Given this list of marker genes Lrrc75b, Itgb8, Rd3l (retinal degeneration 3-like), Asph, Bcl2l11, Foxk2, Fcho2, Kat7, Zfp275, Thsd7a, Ttk, Vegfd, Stam, Slc24a3, Cdc25b, Sbf2, Emx2 (empty spiracles homeobox 2), Mex3c, Mecp2, Kcns2, Rab10, Nfat5, Rarres1, C1galt1, Cdk19, Ppfia2, Trak1, Ubn2, Zc3h12c, Btbd3, Arfip1, Harbi1, Usp47, Cdkn1b, Nptn, Tnrc6a, Atp2b4, Meox2, Klhl7, Ptp4a3, Hnf4g, Epas1, B4galt5, Kdm7a, Mief1, Tmem38b, Npepl1, Cblb, Slc22a15, Cdh4, Itga9, Mbnl3, Errfi1, Cs, Dennd5a, Bcl7b, Ddx3x, Tmem9b (NCBI Gene Id 80508), Cckbr, Macroh2a1, Ppp6r1, Dgkq, Mitf, Avpr1a, Mast4, Kcnd3, Samhd1, Rab6a, Anapc10, D5Ertd579e, Nbea, Tex30, Nme7, Rgs8, Slc39a13, Cstdc2 (NCBI Gene Id 77705), Rfx7, Fryl, Zfp804a, Rc3h2, Gadd45a, Lrp4, Epdr1, Xkr4, Ube2d3, Acp3, Nin, Med28, Arpp19, Dmrtc1c2, Ppp2r3a, Zbtb3, Hmg20a, Crtc3, Rbpj, Camsap1 (NCBI Gene Id 96963), Mdga2, Nova1, Gpatch8, Nalcn, Kmt2e, Parpbp, Lrp2, Hspa4l, Fam234a, Tnrc6c, Mllt6 (NCBI Gene Id 246198), Avpr1b, Ankrd6, Plaa, Atp6v1c1, Trmt1l, Rps6ka3, Gpr174, Col4a1, Cnot6, Dtna, Cbll1, Clspn, Il17rd, Cep350, Smpd3 (NCBI Gene Id 80691), Bmal2, Dmrtc1c1, Naaladl2, Vsnl1, Etnk1, Rictor, Casz1, Itsn2, Zfp462, here is a description of the gene set: Genes predicted to be targets of miRBase v22 microRNA mmu_miR_1960 in miRDB v6.0 with MirTarget v4 prediction scores > 80 (high confidence targets). from publication Chen Y, Wang X (PMID 31504780) Mouse Gene Set: MIR_1960 studied in species Mus musculus